Given this list of marker genes CCAR2, TTI1, TELO2, TTI2, MAP3K20, here is a description of the gene set: Any process that activates or increases the frequency, rate or extent of a DNA damage checkpoint. studied in species Homo sapiens Human Gene Set: GOBP_POSITIVE_REGULATION_OF_DNA_DAMAGE_CHECKPOINT